Given this list of marker genes BMP7 (bone morphogenetic protein 7), BMP2, BMP3, NEO1, BMP5, BMP6, BMP4, PYCARD, CDH5, ELAPOR2, SCUBE3, RSPO2, SRC, here is a description of the gene set: Human Gene Set: GOMF_BMP_RECEPTOR_BINDING Binding to a BMP receptor. studied in species Homo sapiens